Given this list of marker genes POLB, EIF1B, NPEPPS, S100A9, ALOX5AP, DGCR2, HES1, NR1D1, FBN1, GALT, DDB1, HSPH1, ITGAE, JAK3 (Janus kinase 3), PEBP1, IGHM, PFKFB1, MAPKAPK2, TEAD3, RAD50, CPLX2, SARS1, RIT1, DYRK1A, FBLN2, ATOH1, IRAK1, H3-3B, CISH, PSMD8, SS18, ALDH3A2, FGF6, TAF6 (NCBI Gene Id 6878), STARD3, EIF4EBP2, G3BP2, DMAC2L, CYP1B1, LY6E, EZH1, AMD1, RELB, DDX56, DNAJA4, CYP3A4, KPNB1, HMGN1, here is a description of the gene set: Human Gene Set: LEE_CALORIE_RESTRICTION_MUSCLE_DN Down-regulated in the gastrocnemius muscle of aged (30-month) mice subjected to caloric restriction diet since young adulthood. from publication Lee CK, Klopp RG, Weindruch R, Prolla TA (PMID 10464095) The gene expression profile of the aging process was analyzed in skeletal muscle of mice. Use of high-density oligonucleotide arrays representing genes revealed that aging resulted in a differential gene expression pattern indicative of a marked stress response and lower expression of metabolic and biosynthetic genes. Most alterations were either completely or partially prevented by caloric restriction, the only intervention known to retard aging in mammals. Transcriptional patterns of calorie-restricted animals suggest that caloric restriction retards the aging process by causing a metabolic shift toward increased protein turnover and decreased macromolecular damage. species: Mus musculus